The following is a description of a gene set: Mouse Gene Set: MIR_7045_5P studied in species Mus musculus from publication Chen Y, Wang X (PMID 31504780) Genes predicted to be targets of miRBase v22 microRNA mmu_miR_7045_5p in miRDB v6.0 with MirTarget v4 prediction scores > 80 (high confidence targets)., and this is the list of marker genes: Ajap1, Esrrb, Nlgn3, Septin5, Iqgap2 (IQ motif containing GTPase activating protein 2)